Given this list of marker genes FLNA, RHOA (NCBI Gene Id 387), KMT2D, KIF7, TFAP2B, KCNJ2, FAM111A, DVL1, ZMPSTE24, WDR26, KCNJ5, ZBTB7A, WNT5A, LMNA, KDM6A, ZFX, PUS7, TNFSF11, PTH1R, CTSK, CA2, RAB23, EHMT1 (NCBI Gene Id 79813), SFRP4, SRCAP (Snf2 related CREBBP activator protein), STAT3, IL6ST (interleukin 6 cytokine family signal transducer), BCOR, here is a description of the gene set: Persistence of the primary teeth beyond the age by which they normally are shed and replaced by the permanent teeth. Human Gene Set: HP_PERSISTENCE_OF_PRIMARY_TEETH Persistence of primary teeth species: Homo sapiens